The following is a description of a gene set: species: Mus musculus Mouse Gene Set: GOBP_UREA_TRANSPORT The directed movement of urea into, out of or within the cell. Urea is the water-soluble compound H2N-CO-NH2., and this is the list of marker genes: Aqp9, Aqp3 (aquaporin 3), Aqp7, Pou3f3, Slc12a1, Umod, Slc14a1, Slc14a2, Upk3a, Aqp8 (NCBI Gene Id 11833)